The following is a description of a gene set: Human Gene Set: GOBP_POLY_N_ACETYLLACTOSAMINE_METABOLIC_PROCESS The chemical reactions and pathways involving poly-N-acetyllactosamine, a carbohydrate composed of N-acetyllactosamine repeats (Gal-beta-1,4-GlcNAc-beta-1,3)n. species: Homo sapiens, and this is the list of marker genes: GAL3ST3, B4GALT5, B3GNT4, B3GNT7, B3GNT2 (UDP-GlcNAc:betaGal beta-1,3-N-acetylglucosaminyltransferase 2), B3GNT9, B4GAT1, B3GNT3, B3GNT6, B3GNT8